Given this list of marker genes AKT1, GPR101, CTNNB1, PRKAR1A, TSHB, SMO, DDC, TRAF7, BAP1, AIP, SMARCB1, CDH23, BRAF, PRLR, PDE11A, TERT, PIK3CA, NF2, PDGFB, POLR3A, PMM2, MSTO1, SUFU, TRHR, MEN1, SMARCE1, GNAS, here is a description of the gene set: Human Gene Set: HP_INCREASED_CIRCULATING_PROLACTIN_CONCENTRATION The presence of abnormally increased levels of prolactin in the blood. Prolactin is a peptide hormone produced by the anterior pituitary gland that plays a role in breast development and lactation during pregnancy. studied in species Homo sapiens Increased circulating prolactin concentration